The following is a description of a gene set: species: Homo sapiens Reactome Pathway: Signaling by TGF-beta Receptor Complex in Cancer part of: Diseases of signal transduction by growth factor receptors and second messengers Signaling by the TGF-beta receptor complex is tumor suppressive, as it inhibits cell growth and promotes cell differentiation and apoptosis. TGF-beta signaling is frequently impaired in cancer, mostly through SMAD4 gene deletion or loss-of-function mutations (described in the pathway Loss of Function of SMAD4 in Cancer), which are especially frequent in pancreatic cancer. Signaling by TGF-beta receptor complex can also be disrupted by loss-of-function mutations in SMAD2 and SMAD3, as described in the pathway Loss of Function of SMAD2/SMAD3 in Cancer, or loss-of-function mutations in TGFBR2 (TGF-beta receptor II), as described in the pathway Loss of Function of TGFBR2 in Cancer, or TGFBR1 (TGF-beta receptor I), as described in the pathway Loss of Function of TGFBR1 in Cancer.<br><br>In advanced cancer, signaling by TGF-beta may be tumor promoting, as it induces epithelial-to-mesenchymal transition (EMT), thereby increasing invasiveness., and this is the list of marker genes: ZFYVE9, SMAD4, TGFBR1, SMAD2, SMAD3, TGFBR2, FKBP1A, TGFB1